The following is a description of a gene set: Human Gene Set: GOBP_MONOTERPENOID_METABOLIC_PROCESS The chemical reactions and pathways involving monoterpenoid compounds, terpenoids having a C10 skeleton. species: Homo sapiens, and this is the list of marker genes: CYP1A2, CYP3A4, CYP2E1 (cytochrome P450 family 2 subfamily E member 1), CYP2D6, CYP2C19 (NCBI Gene Id 1563), CYP2C9